The following is a description of a gene set: Any process that modulates the frequency, rate or extent of heart contraction. Heart contraction is the process in which the heart decreases in volume in a characteristic way to propel blood through the body. Mouse Gene Set: GOBP_REGULATION_OF_HEART_CONTRACTION studied in species Mus musculus, and this is the list of marker genes: Kcnq1, P2rx4, Cacna1h, Gnao1, Kcnn2, Kcnd3, Hrc, Grk2, Nkx2-5, Myh7, Csrp3, Ada, Kcnh2, Gjc1 (gap junction protein, gamma 1), Chrm3, Scn4b, Myl3 (NCBI Gene Id 17897), Scn2b, Gja5, Zmpste24, Snta1, Adrb2, Abcc9, Adra1b, Slc9a1, Adcy10, Fgf13, Atp5pf, Smad7, Chrna7, Akap9, Bmp10, Thra, Casq2, Scn10a, Tacr3, Atp2a2, Tbx18, Uts2, Bin1, Foxn4, Tnni3k, Calm1, Myh6, Sptbn4, Ehd3, Spx, Kcna5, Ctnna3, Hcn4, Rnf207, Cacna1g, Slc8a1, Slc4a3, Gnai3, Cacna1b, Flna, Scn1b, Nos1ap, Trpv1, Slc1a1, Cav3, Edn2, Agrn, Mdm4, Cacna1d, Pkp2, Oxt, Trpm4, Pln, Nppa, Adrb1, Npff, Src, Atp2a1, Kcnh6, Ffar3, Tmem161b, Irx5, Avpr1a, Dlg1, Sp4, Dmpk, Atp2b4, Rgs2, Cacna1e, Pmch, Thrb, Jup, Gsk3a, Kcne3, Zc3h12a, Ace, Scn3b, Kcne5 (potassium voltage-gated channel subfamily E regulatory subunit 5), Ucn, Glp1r (glucagon-like peptide 1 receptor), Sirt1, Sumo1, Kcnip1 (Kv channel-interacting protein 1), Gjd3, Tmem38b, Ryr2, Prkca, Adra1a, Irx3, Dmd, Hbegf, Agt, Agtr2, Ednra, Ednrb, Cxadr, Kcnj8, Tmem65, Rangrf, Atp1b1, Gpd1l, Chrm2, Nup155, Kcnj2, Hey2, Tgfb2, Apln, Atp1a1 (ATPase, Na+/K+ transporting, alpha 1 polypeptide), Myl4, Tbx5, Nmu, Ank2, Pde5a, Strit1 (NCBI Gene Id 102637511), Crhr2, Pde4d, Tac1, Kcne2, Cacnb2, Kcnj5, Myh7b, S100a1, Tbx2, Gaa, Th, Fkbp1b, Nos3, Rnls, Sri, Gch1, Fxyd1 (NCBI Gene Id 80524), Tmem38a, Akap6, Sema3a, Apela, Cacna1c, Glrx3, Kcne4, Gata4, Bves, Edn3, Gja1, Ccn2, Nos1, Mc3r, Adora1, Cav1, Pik3r1, Smtn, Drd2, Rgs4, Dsc2, Chga, Mef2a, Kcnd2, Shox2, Adra1d, Srebf1, Ptpn1, Kcnip2, Tpm1, Gnai2, Calm2, Cacna2d1, Pebp1, Tnnt2, Atp1a2, Popdc2, Hsp90aa1, Epas1, Scn5a, Edn1, Dsp, Dsg2, Adm2, Mdm2, Ace2, Myl2, Mybpc3, Tnf, Calm3, Kcne1, Tnni3, Hdac4, Isl1, Mir208a, Adm, Hopx, Stc1, Ifng